Given this list of marker genes MIPEP, COX10, LYRM7, PMPCB, YARS1, NDUFS2, HIBCH, ACAD9, SUCLG1, GLRX5, HTRA2, PNPT1, SLC7A7, KARS1, WARS2, NADK2 (NAD kinase 2, mitochondrial), SLC25A12, NDUFA13, SYNJ1, ATP5F1A, ALDH6A1, POLRMT, GFM2, FASTKD2, GTPBP3, NSUN3, MRPL12, MT-ND6, MDH2, COQ8A, MT-CO1 (mitochondrially encoded cytochrome c oxidase I), C1QBP, SARS2, RARS1, SERAC1, MRPS2, COQ9, ATPAF2, CA5A, COQ4, MT-TL1, AMPD2, MT-TI, TPK1, SUCLA2, PRORP, SLC25A4, NDUFS8, MPC1, DTYMK, NDUFA1, COX6A2, SLC25A42, NGLY1, NDUFAF4, CHCHD10, HMGCL, OPA1, COX8A, UPB1, UQCRB, MT-CO3, PNPLA8, TMEM70, GFM1, DARS2, RNASEH1, NDUFS3, LDHA, MT-TP, NDUFC2, ISCA1, TUFM, TANGO2, NDUFAF1, TXN2, MRPL44, AARS2, NDUFA12, MTO1, PITRM1, PC, CLPB, PHKG2, LIAS, MICOS13, NFS1, MT-TN, LETM1, FDX2, AIFM1, PNPO, PDSS1, LRPPRC, PUS1 (NCBI Gene Id 80324), MT-ATP6, COX14, SLC25A3, NDUFAF6, PDSS2, MTFMT, SDHB, GOT2, MT-ND5, OGDH, MRPS7, GYS2, CYC1, RRAGC, FARS2, UQCC2, PDP1, PET117, UQCRH, MPV17, DLD, ADAMTS13, NDUFA8, MT-TS2, COX4I1, TARS2, SLC25A26, TWNK, NFU1, DNM1L, MECP2, FBXL4 (NCBI Gene Id 26235), SLC31A1, TEFM, LIPT2, UQCRQ, COX6B1, HPDL, SCO1, ACAT1, LONP1, RMND1, GK, LIPT1, MRPS28, DGUOK, PDHA1, NDUFS1, HSD17B10, SCO2 (NCBI Gene Id 9997), TMEM126B, NAXE, CARS2, STAT2, MT-TK, OCRL, CDK5, MT-ND3, AMPD1, MT-ND4, DNAJC19, BCS1L, CRAT, NAXD, POLG, NDUFA11, MT-TQ, AGK, TK2, SOD1, NDUFA6, TIMM22, ATAD3A, CYP27A1, NARS2, MT-TV, TRMU, EARS2, PLPBP, MT-TF, NDUFA9, NDUFB8, SFXN4, COX20, MT-TH, MTRFR, POLG2, MT-ND1, SURF1, RRM2B, MRPS16, UQCRC2, NDUFV1, TRMT10C, LARS2, PET100, NDUFB9, HSPD1, SDHA, MRPL39, MT-CO2, IFT56, MT-TL2, HS6ST2, HADHB, SLC25A10, ACACA, UQCC3, MT-ND2, AMPD3, MRPS22, MRPS34, ECHS1, YME1L1, PDHX, MRPS14, RARS2, PRSS12, PPCS, TIMM50 (translocase of inner mitochondrial membrane 50), ISCU, COX5A, YARS2, TRMT5, TSFM, MT-TW, PYGL, MRPL3, COX11, ACAT2, here is a description of the gene set: Abnormally increased level of blood lactate (2-hydroxypropanoic acid). Lactate is produced from pyruvate by lactate dehydrogenase during normal metabolism. The terms lactate and lactic acid are often used interchangeably but lactate (the component measured in blood) is strictly a weak base whereas lactic acid is the corresponding acid. Lactic acidosis is often used clinically to describe elevated lactate but should be reserved for cases where there is a corresponding acidosis (pH below 7.35). species: Homo sapiens Increased circulating lactate concentration Human Gene Set: HP_INCREASED_CIRCULATING_LACTATE_CONCENTRATION